The following is a description of a gene set: from publication Chen Y, Wang X (PMID 31504780) Genes predicted to be targets of miRBase v22 microRNA mmu_miR_9_3p in miRDB v6.0 with MirTarget v4 prediction scores > 80 (high confidence targets). Mouse Gene Set: MIR_9_3P species: Mus musculus, and this is the list of marker genes: Eif4a2, Csde1, Rap2a, Eny2, Tmcc1, Caap1, Pdp1, Gnai2, Pcdha9, Phtf2, Stim2, Fbxo11, Itsn2, Psmf1, Stc1, Slc10a7, Kcns3, Rab9b, Igfbp7, Jazf1, Zbtb33, Zc3h7b, Adipor1, Cpa3, Spopl, Ttc8, Kdm7a, Mkx, Mybl1, Rai2, E2f7, Prss23, Arpp19, Sav1, Ina (NCBI Gene Id 329069), Slc38a2, Gipc2, Tbc1d15, Clasp2, Usp46, Pigk, Cnot6l, Morc4, Larp4b, Ect2, F13a1, Elovl6, Wdtc1, E2f2, Pcdha1, Nxt2, Pou3f2, Lrrc4, Purb, Msantd4, D16Ertd472e, Myo10, Kctd9, Smurf2, E2f1, Pcmtd1, Slc25a51, Mblac2, Apol7c, Ermn, Zfp512, Pcdha3, Gatd3a, Rsf1, Trim36, Pcdha12, Strn3, App (NCBI Gene Id 319425), Elovl5 (NCBI Gene Id 68801), Plxdc2, Pcdh15, Vta1 (NCBI Gene Id 97659), Vezf1, Smarcc1 (NCBI Gene Id 20588), Minar1, Smarce1, Fign, Cert1, Wsb1, Adcy3, Stk4, Gpalpp1, Tmem236, AI593442, Cops2, Pcdha2, Tsc22d4, Cdh8, Plk1, Pcnx1, Foxc1, Myo6, Slc15a2, Yod1, Rapgefl1, Glis3, Strip2, Pan3, Plekhh1, Dmxl1 (NCBI Gene Id 240284), Prkar2b, Cetn2, Dr1, Igf2bp3, Actl6a, Zhx1, Ccser2, Tgfbr1, Cnot6, Sos2, Prl7a2, Dcc, Scai, Aebp2, Gnpnat1, Pcdhac2, Pdzd8, Triap1, Naa20, B230219D22Rik, Dvl2, Fasl, Dmd, Cemip2, Cpd, Rbbp5, Cept1, Clcn4, Rhbdd1, Cdh2, Gm10408, Nexmif, Fam117b, Pcdhb3, Hoxa10, D830030K20Rik, Zfhx4, Fbxo33, Dcbld2 (discoidin, CUB and LCCL domain containing 2), Bmpr2, Mb21d2 (Mab-21 domain containing 2, NCBI Gene Id 98037), Csnk1g3, Sucla2, Cpeb3, Pcdha4, Arl4a, Ubr3, Cep41, Tet1, Stag2, Acsl4, Tirap, Retreg1, Gmcl1, Magi1, Zc3h11a, Pbx3, Emilin2, Hic2, Zfp281, Zdhhc21, Pou2f1, Lhfpl3, Trmt2a, Bhlhe22, Rsbn1, Etl4, Zswim6, Acbd3, Nufip2, Pcdhac1, Tyw5, Qsox2, Tmem64, Zfp799, Pcdha6, Arhgap6, Agfg1, Otud7b, Dcun1d4, Usp12, Gabra1, Prss35, Ripk1, Rfx5, Etnk1, Clock, Slc25a35, Naa15, Cxcl14, Itgb1, Hapln1, Peli1, Tfap2b, Fgf12, Gabpb2, Cux1, Or13e8, Capn7, Stk24, Insm1, Rgs17, Tpd52, Prps1, Mindy3, Pcdha10, Selenot, Washc4, Ythdf1, Dnajc16, Mfsd14a, Dazap1, Srek1ip1, Lrrtm1, Gatm, Rbpj, Zfyve16, Bod1l, Myrf, Dcp1a, Ryr3 (ryanodine receptor 3), Ap3m1, Fsd1l, Fbxo42, Magix, Tcea1, Pax9 (NCBI Gene Id 18511), Plppr1 (NCBI Gene Id 272031), Pcdhb17, Trabd2b, Hspa4, Zfp664, Pcdha11, Pxylp1, Pcdha5, Onecut2, Blcap, Cpe, Kat2b, Pdcl2, Mpeg1, Zcchc2, Hipk3, Zfp113, Sorcs1, Tanc2, Phip, Pth, Syne2, Atp11a, Pcdha8, Antxr2, Anln, Myh10, Herpud1, Aldh1a3, Sptssb, Ing5, Cxxc4, Pfkm, Lypd6, Zfp292, Rab14, Pot1b, Suco, Pcdha7, Acot7, Sftpa1, Lrp6